Given this list of marker genes PPM1K, PTS, CARD6, CWC25, CDHR5, KLHL7, OSTM1, TCEANC, RRAS2, OLIG3, ZBTB24, FYB1, KBTBD11, LSAMP, PTPRA, SEMA3D, POLR1D, ITGB1BP1, NIPAL1, ZFP57, FAM114A2, H2BC21, AMIGO1, DSP, TAF7, RDH14 (retinol dehydrogenase 14), ARHGAP10, KLHL12, MRPL9 (NCBI Gene Id 65005), CASP6, SASH3, POU2F1, KDM5B, USP18, ZNF394, NCBP1, RBM43, CD164, HAVCR1, FAM50A, CRIM1, HMBOX1, RTBDN, NSMAF, BDNF, VPS39, CBFA2T2, GPR27, H3-3A, MCUR1, CCPG1, NEPRO, SNAPC4, SLC45A2, SLC38A11, MAP4K5 (NCBI Gene Id 11183), TBX20, NHLRC3, DAB1, C16orf54, STAT4, FAM120B, CAGE1, FCGR3A, GHDC, WDR33, ZSWIM4, EXTL2, CSTF2T, NID1 (nidogen 1), SMAD5 (NCBI Gene Id 4090), HMX2, AQP11, CNGA1, VPS11, ODAD4, PLCXD2, TASP1, BDH2, LDOC1, PRKACB, NUDCD3, PJA1, CD40LG, GIGYF1, COMMD8, ING5, YJU2B, INPP1, KLB, EEIG2, KLHL1 (kelch like family member 1), EIF2AK1, SLC23A2, ADAM7, SSBP2, SIN3A, MAP3K1, SPATA9, TMEM81, ZSWIM2, TMEM174, NLK, SPINK5, ACTR8, COL14A1, KRT2, CYB5R4, GMEB2, DAGLB, DIS3L2, KLHL42, BACH1, KCNJ2, DNAJC28, FCGRT, HELZ (helicase with zinc finger), ACKR3, NUDT7, PPP1R21, GARIN5A, CHMP3, ELMOD1, ZMYND8, TLR6, CBLL1, TMCC1, ZBTB25, TAT, BBS9, SLC20A1, SAG, GLRB, FRMD6, CST11 (NCBI Gene Id 164378), here is a description of the gene set: from publication Dabrowska A, Kim N, Aldovini A (PMID 19050264) Human Gene Set: GSE12963_UNINF_VS_ENV_AND_NEF_AND_VPR_DEFICIENT_HIV1_INF_CD4_TCELL_UP species: Homo sapiens The high mutation rate of HIV is linked to the generation of viruses expressing proteins with altered function whose impact on disease progression is unknown. We investigated the effects of HIV-1 viruses lacking Env, Vpr and Nef on CD4+ T cell gene expression using high-density DNA microarray analysis and functional assays. Genes up-regulated in control CD4 T cells versus those infected with HIV-1 viruses lacking Env, Vpr and Nef.